Given this list of marker genes SLC16A6, C5orf15, PREP, DGKD, PGGHG, C3AR1, TENM4, RAC2, RNF130, B4GALT1, PID1, PCK2, MGAT4A, DRAM2, MTSS1, ARMC5, B3GNT8 (UDP-GlcNAc:betaGal beta-1,3-N-acetylglucosaminyltransferase 8), RASGRP1, LY86, CXCL1, HRH1, STAT4, ARAP2, ST6GALNAC6, HELZ2, NEURL2, CA13, RALGPS2, HACD1, NUCB1, WWC2, PPARD, APOE, CD72, JCHAIN, RBFOX2, HTRA2, RELL1, PXDC1, SERF1A, SYK, ABCA9, IL7R, DOK2, C1QA, DOCK1, THBS4, CHD9, FCGR3A, PTGR1, IRAK3, SMCO3, LGALS3BP, SLC29A3, KLHL13, GBP7, IL2RG, SCPEP1, P4HB, TICAM1 (TIR domain containing adaptor molecule 1), GGA2, CLSTN1, CXCL11, TNFRSF1A, PCYT1A, BCL3, SEPTIN11 (NCBI Gene Id 55752), LPP, SCAMP1, TIMP2, TMEM65, CLPTM1, MAGI2, COMT, BLNK, UBE2A, OAS1, FCER1G, PDE7B, DLST, TLR1, CD14, C1QB, ARAP3, KIF1B, IRF4, IGKC, ARID5A, SELENOP, PITPNC1, PLXDC2, MS4A6A, EDN1, KLF7, ENG, ETS2, SLC38A1, RAB3IL1, SLC25A33, ARNT, RTP4, LAMTOR4, ATP6AP1, RAI14, GLB1, SDC4, B4GALT5 (NCBI Gene Id 9334), IL4I1, TMEM176B, TMLHE, TM7SF3, MAN2A2, RCN3, MFGE8, IFITM3, CX3CR1, B3GNT2 (NCBI Gene Id 55878), FCGR2A, DAZ2, EDEM1, ATF3, LINC01160, PTGS2, ACER3, FMNL3, LRRC75A, GSTM3, CSF1R, ABHD14B, MICU1, HPGD, RIGI, CALHM6, CLEC5A, LCP2, CTSB, TMEM185A, SLAMF9, RHOH, PDGFB, NDST1, GGH, RNASEH2C, DHX40, CCL4, DCSTAMP, PRPS2, SMOX, VKORC1, CD33, PLAC8, CASP4, C19orf47, MTHFD2L, AUP1, CTSS, MAN1A1, PDPN, TYROBP, DDX1, ACKR3, IL18BP, LRP8, IFITM2, CORO1C, CTPS2, IFI27, BCL2L11, SRXN1, CASP8, SHFL, ACYP2, RILPL1, SPRY1, AKAP1, MS4A7, SULF2, DENND6A, STK11IP, GPR84, KDELR3, RGS7BP, PDE2A, C1QC, FCGR1A (Fc gamma receptor Ia), LGALS9B, TNFRSF1B, RNASEL, TTPAL, LIFR, MYCBP2, NR1H3, SLC7A11, GPR183, METRN, ACP5, ADAM15, GBP4, CHRM3 (cholinergic receptor muscarinic 3), GALK1, here is a description of the gene set: Genes up-regulated in NOD CD4 CD8 double positive thymocyte transgenic for the BDC2.5 TCR incubated with no peptide 0h versus NOD CD4 CD8 double positive thymocyte transgenic for the BDC2.5 TCR incubated with mimetope negative sel 16h. Human Gene Set: GSE2128_CTRL_VS_MIMETOPE_NEGATIVE_SELECTION_DP_THYMOCYTE_NOD_UP from publication Zucchelli S, Holler P, Yamagata T, Roy M, Benoist C, Mathis D (PMID 15780994) Fetal thymic organ culture (FTOC) DC2.5 CD4+CD8+ thymocytes from B6g7 or NOD background. 0 or 16 hour after addition of the BDC mimitope studied in species Homo sapiens